Given this list of marker genes BBS1, EFEMP1, TLCD3B, GUCA1A, POMGNT1, RS1, CCDC28B, ARL6, GUCY2D, ARSG, PRPH2, KIAA1549, CFI, CFH (complement factor H), KIF3B, CFAP418, IDH3A, here is a description of the gene set: species: Homo sapiens Human Gene Set: HP_HYPERAUTOFLUORESCENT_RETINAL_LESION Increased amount of autofluorescence in the retina as ascertained by fundus autofluorescence imaging. Hyperautofluorescent retinal lesion